The following is a description of a gene set: species: Mus musculus Mouse Gene Set: GM14443_UNIPROT_A2ARX0_UNREVIEWED_TARGET_GENES from publication Yevshin I, Sharipov R, Kolmykov S, Kondrakhin Y, Kolpakov F (PMID 30445619), and this is the list of marker genes: AU041133, Mir25, Zbtb38 (zinc finger and BTB domain containing 38), Mir106b, Gm6483, Gm5100, Sorbs2, Mir93, Mcm7, Runx3